The following is a description of a gene set: studied in species Homo sapiens Human Gene Set: GOBP_INFLAMMATORY_RESPONSE_TO_ANTIGENIC_STIMULUS An inflammatory response to an antigenic stimulus, which can be include any number of T cell or B cell epitopes., and this is the list of marker genes: RBPJ, LTA, PSMB4, FYN, IL5RA, RASGRP1, MIR19A, CD81, EXT1, HLA-DRB1, ZP3, SPN, PSMA1, FURIN, IGHE, NPFF, TREX1, MAPK14, PLA2G2D, MIR19B1, MIR105-1, CD68, FCGR3B, MIR302E, FCGR1A, LYN, HMGB2, FOSL2, CCR7, GNAS, TREM2, FCGR2C, KARS1, CD6, FCGR2A, GPX1, HMGB1, IL10, NPY, NOTCH1, MIR6869, IL31RA, NLRP6, MKRN2, NOTCH2, GPR17, FCER1A, PLK2, PNMA1 (NCBI Gene Id 9240), NPY5R, FCGR2B, PARK7, RAB44, HLA-E, TNF, SELENOS, IL12B, RHBDF2, CD28, SYK, IL2RA, PLCG1, YES1, FCGR3A, KDM6B, IL20RB (NCBI Gene Id 53833), FGR, C3, IGHG1, ELANE, IL25, SRC (SRC proto-oncogene, non-receptor tyrosine kinase), HCK, FCER1G, BTK, FUT7, GATA3, CYSLTR1, FCGR1BP